Given this list of marker genes CA7 (NCBI Gene Id 766), AHCYL1, TRPA1, RAB11B, GOPC, PRKG2, PDZK1, ATP8B1, STC1, CA2, TCAF1, CFTR, ABCB1 (ATP binding cassette subfamily B member 1), TCAF2, GABRE, here is a description of the gene set: Human Gene Set: GOBP_REGULATION_OF_MONOATOMIC_ANION_TRANSPORT species: Homo sapiens Any process that modulates the frequency, rate or extent of the directed movement of anions, atoms or small molecules with a net negative charge into, out of or within a cell, or between cells, by means of some agent such as a transporter or pore.